The following is a description of a gene set: studied in species Homo sapiens An abnormal elevation of the concentration of thyroglobulin, a protein produced in the thyroid gland that acts as a precursor to thyrroid hormones. Human Gene Set: HP_INCREASED_CIRCULATING_THYROGLOBULIN_CONCENTRATION Increased circulating thyroglobulin concentration, and this is the list of marker genes: FOXI1, SLC26A4, PAX8, THRB (NCBI Gene Id 7068), SLC35A2, KCNJ10, DUOX2, GLIS3, TSHR